Given this list of marker genes SNW1 (SNW domain containing 1), PTCD3, DCUN1D5, ADSS2, PSMC2 (NCBI Gene Id 5701), TEX30, NUP93, CSTF1, QDPR, WDTC1, NDUFS6, VARS1, NDUFB4, TSG101, KIAA1958, C9orf78, ATPAF2, GTF2E2, ATP5MC2, CKAP5, KYAT3, RPGR, MRPS9, MTHFD1L, ROMO1, SLC35E3, MRPL45, ENKD1, GTF2F2, ALDH16A1, TUBG1, TXNL4A, COX18, HINT1, SENP8, PSRC1, STX12, HMBS, PRADC1, ERCC6L, WDR3 (NCBI Gene Id 10885), RPL36A, GDI2, WDR70, TBL1XR1, PDCD5, GPD1L, ANKRD13B, GTF2H5, WDR75, FGR, UBE2L3, CCDC40, ZRANB3, NCBP3, THAP11, DEGS2, DAZAP1, PCNX4, DDX49, PELP1, DHFR, CDKN2AIPNL, NT5M, TMEM11, SUPV3L1, DRG2, OBI1, UCHL3, DHX29, PHB1, TTC27, YPEL2, TBP, CDCA7L, RAB1A (NCBI Gene Id 5861), ILF2, CEP128, AP4E1, PHB2, SLC25A10, UMAD1, CLASP1, NMD3, PMPCB (NCBI Gene Id 9512), PPA1, IPMK, CRELD2, SELENOM, CENPM, DHRS13, BRPF3, SRSF9, CARHSP1, LIG3, EIF3A (NCBI Gene Id 8661), NTMT1, FAM98B, PHF10, EXOSC9, PSMA7, PSMA3 (proteasome 20S subunit alpha 3), MYDGF, FEM1B, NEDD4, EIF3K, FBXO7, HBS1L, SF3B5, DNAJC2, TXNDC5 (thioredoxin domain containing 5), SFR1, RPL18A, PCBP1, BCAT1, RNF126, RPS5, MRPL51, PFDN6, SF3A3, AIFM1, DIPK1B, SLAMF6, CSE1L, ARL6IP6, PFAS, THEM6, SNRPF, RBM19, MRPL22, AUH, SUB1, CFAP298, CPSF6, SIN3B, CCP110, ACSL5, JADE3, PSMA5, NAA20, TCF4, CHCHD7, RAD50, INTS15, DNAJC15, SMC3, MICOS10, GINS1, ZFAND4, ERI3, PHF5A, VRK1, NKAP, SCPEP1, OARD1, DNTTIP2, SPIDR, KNOP1, ANO6, ZNG1B, PTAR1, LTV1, HMCES, RNF168, TFDP2, PPAT (phosphoribosyl pyrophosphate amidotransferase), PTOV1, DHDDS, DIS3, SLC25A3, SELENOH, SLC7A1, HEATR3, RMDN3, RWDD4, MGAT4B, DPY30, MALSU1, HDAC1, UBE2A, NUP133, AHCTF1, RPS6KA5, CFAP20, GRWD1, FUNDC1, TARS2, POLR2D (NCBI Gene Id 9393), GTF3C4, NAA38, ZFP41, ERI1, EPB41L4A, CAMKV, CENPS, SRSF7, RPGRIP1, MTHFD1, THRA, HNRNPM, here is a description of the gene set: studied in species Homo sapiens Human Gene Set: GSE31082_DN_VS_CD4_SP_THYMOCYTE_UP Genes up-regulated in comparison of CD4- CD8- thymocytes versus CD4+ CD8- thymocytes. from publication Egawa T, Littman DR (PMID 21873191) Mouse thymocytes can be classified into four major subsets based on expression of CD4 and CD8 co-receptors. CD4-CD8- (double negative, DN) cells become CD4+CD8+ (double positive, DP) cells following productive T cell receptor (TCR) beta chain rearrangement. A small proportion of DP cells are selected through interaction of clonal TCRalpha/beta and MHC self peptide complex expressed on thymic stromal cells. DP cell expressing MHC class I-restricted TCR become CD4-CD8+ cells, which will finally differentiate into cytotoxic T cells, while MHC class II restricted selection generates CD4+CD8- helper lineage T cells. We used microarrays to identify genes important for thymocyte differentiation and lineage determination by profiling gene expression in different thymocyte subsets.